The following is a description of a gene set: studied in species Mus musculus from publication Chen Y, Wang X (PMID 31504780) Mouse Gene Set: MIR_466Q Genes predicted to be targets of miRBase v22 microRNA mmu_miR_466q in miRDB v6.0 with MirTarget v4 prediction scores > 80 (high confidence targets)., and this is the list of marker genes: Ino80d, Cnep1r1, Cpeb4, Foxk2, Pkib, Elk4, Zfc3h1, Flvcr2, Ncr1, Rc3h1, Tent4a, Daam1, 2210408I21Rik, Or5k1, Snx25, Mapk6, Hivep1, Fhip2a, Hps6, Lifr, Hdc, Smc1a, Hif3a, Tulp4, Ndufs1, Appl1, Lancl2, Grin3a, Mapk8, Nckap5, 5730409E04Rik, Nrg3, Med13l, Fancf, Pcdh8, A830018L16Rik, Togaram1, Sumo1, Seh1l, Ahdc1, Tmco3, Myt1l, Wasl, Bach2, Syngr1, D16Ertd472e, Rbpms2, Fzd10, Nphp1 (NCBI Gene Id 53885), Pcgf3, Morc3, Trim35, Vps26a, Meis2, Adam10, Reps2, Srsf3, D5Ertd579e, Avl9, Rad21, Mis18bp1, Igf1r, Tars3, Mospd2, Fam43a, Rev3l, Nodal, Tet2, Ccnb1ip1, Aak1, Ube2w, Scara3, Nufip2, Mbnl1, Tob1, Dmxl1, Mtrf1l, Tmem178b, Mlxip, Map1b, Ptprk, Brwd3, Kmt5b, Mamdc2, Rora, Srsf12, Hand2 (NCBI Gene Id 15111), Abtb3, Fmr1, Xrn1, Nnat, Cemip2, Tent4b, Dynlt3, Adamts15, Rps3, Pde9a, Jmy, Dlgap1, Wac, Exd2, Cdk5rap2, Kcnk5, Dcun1d4, Pnma2, Kmt2c, Uqcc4, Spin1, Kcnb1, Wars1, Bnc2 (NCBI Gene Id 71498), Cacna1b, Bmpr1b, Chic2, Sema6d, Slc25a36, Plekhb2, Ccnl2, Ccdc6 (NCBI Gene Id 76551), Kif3a, Gfpt2, Itpr1, Psd4, Zfp1008, Bmper (NCBI Gene Id 73230), Cry2, Cask, Blcap, Syt14, Sycp2, Wdfy3, Atoh8 (atonal bHLH transcription factor 8), Stac, Btg2, Prkg1, Tbc1d1, Zfp326, Slc24a3, Xxylt1, Fbxl17 (NCBI Gene Id 76180), Prkar1a, Trpm7, Ilrun, Gramd2b, Peak1, Gdf11, Pcdh7 (protocadherin 7), Syne1, Adcyap1, Sema6b, Nup58, Gpc6, Tmem64, Zcchc2, Baz1a, Pou2f1, Aida, Brd3, Timm22, Gm5544, Ints2, Bltp1, Amotl1, Slitrk5 (SLIT and NTRK-like family, member 5), Kdm1b, Vsnl1, Hipk3, Zdhhc20, Arid1b, Trim33, Ergic2, Usp28, Aif1l, Olfml2b, Dnajb9, Pknox2, Cers6, Csmd1, Tbc1d22a, Snn, Raph1, Tnrc18